The following is a description of a gene set: studied in species Homo sapiens Mildly elevated creatine kinase Human Gene Set: HP_MILDLY_ELEVATED_CREATINE_KINASE, and this is the list of marker genes: CHCHD10 (coiled-coil-helix-coiled-coil-helix domain containing 10), PLEKHG5, GNE, ALG2, COL25A1, GABRA3, PEX6, KBTBD13, NEB, COL9A3, DNM2, GFPT1, CRPPA, KLHL41, POLG, KCNJ18, TPM3, SNUPN, MYH7, DOK7, HNRNPA1, COL12A1, MT-TL2, TFG, KCNE3, VCP, ADSS1, LMNA (lamin A/C), COL6A1, MT-TE (mitochondrially encoded tRNA-Glu (GAA/G)), UBA1, HADH, BIN1, YME1L1, SQSTM1 (NCBI Gene Id 94002), MYPN, MYH14 (myosin heavy chain 14), TPM2, QRICH1, MYF6, TRMU, MTMR14, MT-TN, FILIP1, MPV17, RYR1, POMT1, MT-TL1, FKTN, POLRMT, SCYL2, TTN, SCN4A, MICU1, MSTO1, FLNC, TRIP4, MEGF10, TBCK (NCBI Gene Id 93627), CACNA1S (NCBI Gene Id 779), FKRP, ACTA1 (NCBI Gene Id 58), MATR3, TWNK, ERGIC1, TIA1